The following is a description of a gene set: TGF-beta3 produced by developing Th17 cells induces highly pathogenic T cells that are functionally and molecularly distinct from TGF-beta1-induced Th17 cells. The microarray data represent a distinct molecular signature for pathogenic versus non-pathogenic Th17 cells. studied in species Homo sapiens from publication Lee Y, Awasthi A, Yosef N, Quintana FJ, Xiao S, Peters A, Wu C, Kleinewietfeld M, Kunder S, Hafler DA, Sobel RA, Regev A, Kuchroo VK (PMID 22961052) Genes down-regulated in comparison of untreated CD4 T cells versus those treated with TGFB3 IL6. Human Gene Set: GSE39820_CTRL_VS_TGFBETA3_IL6_CD4_TCELL_DN, and this is the list of marker genes: SMIM20, PYGL, SIRT7, KCMF1, MAPK9, CNPPD1, DDR1, AVPI1, LPXN, RNF181, REXO4, SUN1, WDR81, WDR1, TNFAIP8L1, SEC31A, CREB3L2, PTPRJ, BLVRB, HEMK1, ZBTB21, IFNAR2, ABAT, MCFD2, TREML2, SUSD3, SLC12A7, UTP14A, ECM1, RORA, DHRS1, RBBP8, ARMCX3, GRAMD1A, ACAP1, PPP1R3B, CARHSP1, CDR2, MT1E, DUSP22, GKAP1, ACOT8, NSF, SAG, GALNT6, NUDT18, NCS1, FNDC3A, NDUFAF3, MAP2K6, TAX1BP3, RAB26, ETV6, MAGED2, FRMD4B, ZBTB7B, UBQLN1, SEMA4F, ZBED3, DAZAP2, TUBA8, SNAPC1, WDR47, CYSLTR1, PLA2G12A, XRCC4, SEC24D (SEC24 homolog D, COPII coat complex component), PRNP, DENND10, DNAH11, IFT43, CORO7, AKAP13, CSRNP1, NCBP2AS2, YPEL3, ID2, FLOT1, CTNNA1, TBCEL, IL21, IL21R, PEX13, PTPN1, CHM, GEM, STK38L, LIME1, CAMKK1, MT2A, ZEB1, FOSL2, CAST, KLHL6, RAB2A, FAU, UBE2F, ITGA3, PRRC1, IL17A, SRA1 (steroid receptor RNA activator 1), SERPINB1, TSPAN6, SNORD89, GATM, STX18, SMIM14, RNH1, TGM1, COPG2, MGRN1, SLC30A4, RBMS2, CACFD1, RBM7, PYCR1, MTMR7, SRGAP3, CA5B, UPP1, RRM2B, PPP1R15A, PICALM, NFE2L2, ECI2, TULP3, TIMP1, TMEM107, SYT11, ANXA2, IYD, RBM22, SEC24A, ADPRM, MGARP, CCDC186, GGACT, PSMC6, ZDHHC18, STOML1, SMAD3, NTPCR, DCTN4, ATRNL1, ACVR1B, SMOX, FURIN, COPA, AIMP1, PAPSS1 (NCBI Gene Id 9061), PPM1J, ARFGAP3, MYO10, BNIP5, HDAC5, ACBD4, METTL23, TBC1D19, TBC1D22A, DNPEP, NAGK, NICN1, NDRG2, PTTG1IP, ARRB1, TLE6, VAX2, PLEKHG2, IER3, CCDC6, ZFP36L2, KLF9, RABGGTA, SERPINE1, AMZ2, GPR18, MARCHF7, UBE2H, CTSB, TRPM4, SH3GLB1, ENTREP3, PHF20, SMPD1, AFG3L2, BLNK, WDFY2, MCTP2, CYFIP2, PLSCR3, NDRG1, CDC14B, S1PR3, TMUB2, CDKN2D, CCDC63, YPEL5, ORMDL3 (NCBI Gene Id 94103), TMEM205, BABAM2